Given this list of marker genes OCRL, PLEC, ITGB4, CRB2, CYP11A1 (cytochrome P450 family 11 subfamily A member 1), POR (cytochrome p450 oxidoreductase), RNF13, IARS1, here is a description of the gene set: species: Homo sapiens Abnormal maternal serum screening Human Gene Set: HP_ABNORMAL_MATERNAL_SERUM_SCREENING An abnormally elevated or decreased level of a maternal serum marker analytes used in screening for aneuploidy.